Given this list of marker genes B9D2 (NCBI Gene Id 80776), IFT122, DCDC2, MKS1, NEK8, ZFYVE19, TMEM67, NPHP3, here is a description of the gene set: Malformation of the hepatic ductal plate species: Homo sapiens Human Gene Set: HP_MALFORMATION_OF_THE_HEPATIC_DUCTAL_PLATE